The following is a description of a gene set: Genes down-regulated in livers injected with IL6: SOCS3 knockout versus wildtype. Changes in mouse liver mRNA profiles following intraperitoneal cytokine injection. Either interferon-gamma-/-, albumin-cre(-) Socs3(w/fl) mice, or albumin-cre(+) Socs3(-/fl) mice were injected with either phosphate-buffered saline, interferon-gamma, or interfeukin-6, and livers taken after 4h. from publication Croker BA, Krebs DL, Zhang JG, Wormald S, Willson TA, Stanley EG, Robb L, Greenhalgh CJ, Förster I, Clausen BE, Nicola NA, Metcalf D, Hilton DJ, Roberts AW, Alexander WS (PMID 12754505) studied in species Homo sapiens Human Gene Set: GSE369_SOCS3_KO_VS_WT_LIVER_POST_IL6_INJECTION_DN, and this is the list of marker genes: HIVEP1, CD74, SLC25A53, TP53INP2, HDAC9, MEF2D, PIAS1, WTAP, STRADB, NUSAP1, SNN, SLC12A3, ATP6V1D, TAPT1, SBK1, LY6D, WASF2, CDKN2D, FAM184B, BIRC3, PRKCE, ZDHHC2, H3C7, PPP1R21, GPR18, B3GNT2, SLC14A1, RNASE6, BMP2K, MBD4, PLEKHA2, LSP1, PMFBP1, HLA-DQA1, MXD3, SLAMF9, COL5A3, AFF3, AP1S3, MCTP2, BCOR, TRIM26, CERK, CHST15, UCHL1, MACIR, CCND2, ASAP3, TNFRSF13B, EAF2, PCP4, FRYL, DGKE, MRC1, KRT86, HERC3, FBXO33, MTMR1, IQCB1, GDPD3, TINF2, PRKCB, PLD4 (phospholipase D family member 4), PSAP, LGR5, SEMA4B, CD22, FBXL5, RPIA, NFATC3, FOXP1, GSDMD, LIG4, FTX (FTX transcript, XIST regulator), RANBP9, MYL4, MYCN, H3C14, SLC25A44, IKZF1, PPM1E, PECAM1, PPP2R5A, ELL2, ELF1, NAPSA, MAST2, POLM, THBD, PHF8, ZCCHC18, FCMR, MANEA, FAM204A, ADAM19, VEZF1, STX7, TRAM1, CD93, ARHGAP17, KLHL24, IL22RA2, TMEM243, SLC37A2, CSRP3, JCHAIN, BACH2, HLA-DMB, SRRD, SLPI, PRKCG, GBP4, MYBPC2, ALPK2, PIK3AP1, ST8SIA4, CHML, STX11, TXNDC16, SUB1, FAM107B, ANKLE2, GPR3, SIGLEC10, PLEKHM3, WSB1, NIBAN3, CD38, PKIG, CBLB (NCBI Gene Id 868), CECR2, EPS8, RIPK2, MED10, S1PR1, DCUN1D3 (NCBI Gene Id 123879), CDKN3, GPR155, ZNF558, TMEM123, PAFAH1B3, BLVRB, CYTH1, MAP3K1, PIPOX, LYN, VAV3, PRKD3, OSTM1, P2RY12, GDAP2, CCR7, RNF122, IGLC7, RB1, GNPTAB, TAX1BP1, EGFL6, UBAC2, TLR7, FCRLA, TREML2, ALDH1B1, CD36, WBP1, GPCPD1, TANK, SPIB, IFT22, RHD (NCBI Gene Id 6007), TTPAL, SORL1, KCNA3, KLHL6, LMO2, NFKBIE, SLBP, MSI2, CNP, FICD, UNC119B, ABHD17B, B3GNT5, CTSS, HLA-DRB1, TIFA, CEP120, HEATR6, HSPA2, DPP4, H3C4, PTGR1, SMIM14, MEF2C, RGS2, PDE7A, SLC30A5, LPXN, TKTL1, ZUP1